The following is a description of a gene set: Human Gene Set: REACTOME_SARS_COV_1_INFECTION SARS-CoV-1 Infection species: Homo sapiens, and this is the list of marker genes: BCL2L1, SFN, CHMP7, PPIG, ZCRB1, MOGS, FAU, RPS4X, YWHAG, GALNT1, NPIPB3, BST2, RPS27L, CHMP2B, CHMP4B, UBA52, EEF1A1, FKBP1A, IFIH1, GSK3A, BECN1 (NCBI Gene Id 8678), PALS1, TOMM70, VCP, VHL, RPS18, UVRAG, PARP16 (NCBI Gene Id 54956), RPS3A, RPS14, PRKCSH, PARP14, UBE2I, PSMC6, TLR7, GSK3B, NPM1, UBB, MAVS (NCBI Gene Id 78993), TMPRSS2, RUNX1, CAV1, PARP10, IKBKE, TKFC, IRAK2, PARP6, RPS8, ST6GALNAC3, PPIA (NCBI Gene Id 5478), SP1, RELA, PIK3C3, NFKBIA, SIKE1, PARP9, TBK1, RPS26, RPS28, RPS4Y2 (ribosomal protein S4 Y-linked 2), YWHAH, CHMP2A, SERPINE1, ITCH, RPS23, TRAF3, PARP8, SMAD3, ST3GAL1, PYCARD, RIGI, IRF3, RPS5, ST3GAL2, SMAD4, RPS7, RPS27, TRAF6, YWHAZ, UBC, SUMO1, YWHAB, RPS19, PPIH, PDPK1, NFKB1, PKLR, MAP1LC3B, RB1, RPS29, RPS21, PPIB, STING1 (NCBI Gene Id 340061), MGAT1 (alpha-1,3-mannosyl-glycoprotein 2-beta-N-acetylglucosaminyltransferase), RPS17, PARP4, CTSL, ACE2, RPS9, TRIM25, NMI, CHMP4A, CHMP4C, CASP1, PCBP2, DDX5, RPS12, YWHAQ, RPS15A, CANX, RPS16, HNRNPA1, RPS15, NLRP3, RPS11 (NCBI Gene Id 6205), PIK3R4, ST6GALNAC4, GANAB, ST6GALNAC2, RPS3, RPS13, ST6GAL1, RPS27A, RPS10, RPS24, KPNA2 (karyopherin subunit alpha 2), RPSA, YWHAE, CHMP6, SFTPD, RIPK1, KPNB1, CHMP3, RPS2, RIPK3, RPS4Y1, RPS6, EP300, RPS20, RPS25, RCAN3, ST3GAL3, ST3GAL4